The following is a description of a gene set: Human Gene Set: GOMF_TRANSCRIPTION_ELONGATION_FACTOR_ACTIVITY species: Homo sapiens A molecular function that stimulates the elongation properties of the RNA polymerase during the elongation phase of transcription. A subclass of transcription elongation factors enable the transition from transcription initiation to elongation, while another class rescue stalled RNA polymerases., and this is the list of marker genes: POLR2M, TCERG1, VHL, WDR43, TEFM, EAF2, CDK9, EAF1